Given this list of marker genes GREM2, PRKACB, MACIR, TOX4, AGFG1, COL6A5, ASXL2, FBXL20, ERVH48-1, PCDH10, OAZ3, DCTN4, SDHD, RFXAP, STEAP2, SIX4 (SIX homeobox 4), EIF1AX, PAGE4, GDI1, MBL2, UNK, OSBP, DNAJC16, GPR83, SLC39A14, UBE3D, EDA, AJAP1, CCDC85A, PHLPP1, ZSWIM6, TENM1, GNGT2, SMG1, VPS53, LIX1, SLC35F1, MRPL10, UNC5C, AGAP3, SLC16A10, CHIC1, CCNYL1, RBIS, ASAP2, SRGAP3, TMCC2, METAP2, here is a description of the gene set: Genes predicted to be targets of miRBase v22 microRNA hsa-miR-5571-3p in miRDB v6.0 with MirTarget v4 prediction scores > 80 (high confidence targets). from publication Chen Y, Wang X (PMID 31504780) species: Homo sapiens Human Gene Set: MIR5571_3P